Given this list of marker genes FGF10, WDR36, FGFR2, CYP1B1 (NCBI Gene Id 1545), OPTN, POLG2, EFEMP1, FGFR3, NTF4, MYOC, ASB10, LMX1B, here is a description of the gene set: Open angle glaucoma A type of glaucoma defined by an open, normal appearing anterior chamber angle and raised intraocular pressure, Human Gene Set: HP_OPEN_ANGLE_GLAUCOMA species: Homo sapiens